The following is a description of a gene set: Mouse Gene Set: GOMF_RNA_CAP_BINDING Binding to a 7-methylguanosine (m7G) group or derivative located at the 5' end of an RNA molecule. species: Mus musculus, and this is the list of marker genes: Ago2, Eif3d, Larp1, Cyfip2, Eif4e3, Fmr1 (fragile X messenger ribonucleoprotein 1), Gemin5, Ncbp3, Cyfip1, Eif4e, Mcts1, Ncbp1, Dcps, Ncbp2, Eif4e1b, Eif4e2